The following is a description of a gene set: Human Gene Set: GOBP_HYPOTONIC_RESPONSE Any process that results in a change in state or activity of a cell or an organism (in terms of movement, secretion, enzyme production, gene expression, etc.) as a result of detection of, or exposure to, a hypotonic environment, i.e. an environment with a lower concentration of solutes than the organism or cell. studied in species Homo sapiens, and this is the list of marker genes: SLC12A6, FBP1, TRPV4, SLC4A11, OXSR1, MYLK (NCBI Gene Id 50483), CAB39, CLCN2, TSPO, ITGA2, SLC12A5, STK39 (NCBI Gene Id 27347), AQP5